Given this list of marker genes EDC3, ZFP36L1, PNRC2, DCP1A, ZFP36, EDC4, DCP1B, here is a description of the gene set: studied in species Homo sapiens Human Gene Set: GOBP_NUCLEAR_TRANSCRIBED_MRNA_CATABOLIC_PROCESS_DEADENYLATION_INDEPENDENT_DECAY A pathway of degradation of nuclear-transcribed mRNAs that proceeds through a series of steps that is independent of deadenylation, but requires decapping followed by transcript decay, and that can regulate mRNA stability.